Given this list of marker genes TRAK1, SLC1A3, FBXO48, PBX1, ODAD4, ANKRD61, TRIM52, DCP1B, KCNK18, ATXN7L1, SORL1, ABCD4, SFRP4, IPO5, INF2, LSP1, MIR496, MED24, RANBP10, RIN1, EIF2S2, RRP1B, SLC12A2, UBAP2L, DEFB4A, PML, PPP1R37, TRIM40, ATP6V0A2, MOSPD3, NOD1, SNED1, DOP1B, SETD1A, FAM117B, MLXIP, FLNB, HAUS2, VAMP2, ZFYVE19, ZMYND12, SLITRK2, CCDC115, TSPAN1, SH3RF1, RNF185, LRRC8B, HIPK2, TLE1, PTK2B, ZCCHC2, SMAD3, MINPP1, WRAP73, DDX54, KRTAP7-1, FGA (fibrinogen alpha chain), NGFR, FAS, WDR86, FAM168B, SHBG, BRIP1, SLC45A2, CEP68, SERPINI2, LCN8, CFAP100, UFSP1 (NCBI Gene Id 402682), LRRC7, REG3A, NET1, MAPKAP1, CEP126, EAF1, P3H3, ZIC3, SUSD1, CYLC1, RPS6KA2, CACNB3, FMNL1, ZFP57, HGS, CBFA2T2, MRO (NCBI Gene Id 83876), ZHX2, CMA1, PSMA2, UBQLN1 (ubiquilin 1), NEU4, INPP5A, NEB, RHBDL1, SUFU, ALLC, DRP2, TAF8, KLHL38, NPAS4, TMC5, CCNO, RBBP5 (NCBI Gene Id 5929), SPEN, ATP6V0D1, PRKAR2A, ZYG11A, TMEFF2, PDP2, F2R, SH3BP5, CLCA4, ADAM5, RNF222, MCM3AP, ETV1, NCOR2, ACTN2, SCLY, STAT3, MDM1, HDX, PLN, USP42, RGS18, RFTN1, LNX2, TRIM26, NF1, CLEC1A, SIN3A, PRSS58, HDLBP, GATC, here is a description of the gene set: Myeloid dendritic cells (DC) and macrophages play an important role in pathogen sensing and antimicrobial defense. Recently we demonstrated that infection of human DC with intracellular bacterium Listeria monocytogenes (L.monocytogenes) leads to the induction of the immunoinhibitory enzyme indoleamine 2,3-dioxygenase (Popov et al., J Clin Invest, 2006), while in the previous studies L.monocytogenes infection was associated with a rather stimulatory DC phenotype. To clarify this discrepancy we performed comparative microarray analysis of immature mo-DC (immDC), mature stimulatory mo-DC (matDC) and mature inhibitory DC either stimulated with prostaglandin E2 (PGE2-DC) or infected with L.monocytogenes (infDC). Studying infection of human myeloid DC with Listeria monocytogenes, we found out, that infected DC are modified by the pathogen to express multiple inhibitory molecules, including indoleamine 2,3-dioxygenase (IDO), cyclooxygenase-2, interleukin 10 and CD25, which acts on DC as IL-2 scavenger. All these inhibitory molecules, expressed on regulatory DC (DCreg), are strictly TNF-dependent and are in concert suppressing T-cell responses. Moreover, only DCreg can efficiently control the number of intracellular listeria, mostly by IDO-mediated mechanisms and by other factors, remaining to be identified. Analyzing publicly acessible data of transcriptional changes in DC and macrophages, infected by various pathogens and parasites (GEO, GSE360), we noticed that infection of these cells with Mycobacterium tuberculosis causes transcriptional response, comparable with the one caused by listeria in human DC. In fact, granuloma in tuberculosis and listeriosis in vivo are enriched for myeloid DC and macrophages characterized by regulatory phenotype. In summary, regulatory myeloid DC and macrophages may play a dual role during life-threatening granulomatous infections, such as tuberculosis: on one hand, regulatory myeloid cells promote pathogen containment by efficiently killing intracellular bacteria, on the other hand these cells inhibit granuloma-associated T cells and thereby might be involved in the retention of TNF-controlled granuloma integrity protecting the host from granuloma break-down and pathogen dissemination. studied in species Homo sapiens from publication Popov A, Driesen J, Abdullah Z, Wickenhauser C, Beyer M, Debey-Pascher S, Saric T, Kummer S, Takikawa O, Domann E, Chakraborty T, Krönke M, Utermöhlen O, Schultze JL (PMID 18802101) Human Gene Set: GSE9946_LISTERIA_INF_MATURE_VS_PROSTAGLANDINE2_TREATED_MATURE_DC_UP Genes up-regulated in mature inhibitory dendritic cells: L. monocytogenes infection versus prostaglandin E2.